The following is a description of a gene set: species: Homo sapiens Genes up-regulated in tumor associated macrophages conditioned by: glioblastoma versus colorectal adenocarcinoma. Active immunotherapy is a promising strategy for anti-angiogenic cancer therapy. Recently, we have reported that a vaccine using human umbilical vein endothelial cells (HUVECs) induced specific anti-endothelial immune responses in the most of immunized patients, and resulted in tumor regression in some patients with recurrent malignant brain tumors, whereas not in colorectal cancer patients. In this study, we hypothesized that non-hypoxic perivascular tumor associated macrophages (TAMs) in colorectal cancer, but not in glioblastoma, might negatively alter the therapeutic efficacy of anti-angiogenic active immunotherapy. To test this hypothesis, we examined global gene expression profiles of non-hypoxic macrophages stimulated in vitro by soluble factors released from tumor cells of human glioblastoma U-87MG (‘brain TAMs’) or colorectal adenocarcinoma HT-29 (‘colon TAMs’). Human Gene Set: GSE18804_BRAIN_VS_COLON_TUMORAL_MACROPHAGE_UP, and this is the list of marker genes: CYP26B1, PIGN, EDIL3, TMEM185A, DDX60L, SEM1, PSG4, TCEAL7, STOML1, SSTR5 (NCBI Gene Id 6755), BEX1, E2F7, EGR3, AMIGO1, KANSL3, BSN, OTUD1, TRIB3, PUDP, ANO2, RAB9A, EFS, PLK2, ITGB2-AS1 (NCBI Gene Id 100510549), PSMB3, MPP3, CEP41, CD70, RAB40C, MAPRE1, SCN7A, FA2H, CDKN1C, SFRP1, TBL1XR1, LMCD1, PALLD, UTY, WDR48, FUNDC1, SRRM4, ST7L, CBFB, POLR3F, MYT1, DHX40, CALB1, LINC00582, SPATA17, PSMC2, TMEM178B, LYPD6, AMPH, PIGA, LINC02381, PRRX1, SLC35A5, KCNJ4, LOXL1-AS1, SLPI, TPSD1, SSR4 (signal sequence receptor subunit 4), PPP1R9A, SYTL5, PITPNM3, PTAFR, TMCO3, B3GALNT1, ZXDC, ARPC1A (actin related protein 2/3 complex subunit 1A), ZNF83, NAP1L3, CCNL1 (cyclin L1), LPCAT2, DLG5-AS1, MIEN1, PMEL, CALCR, LRRC8D, GPNMB, BECN1, AGK, PEX11B, ELOVL7, ABLIM2, SH2D4B, KIF9, TRMT10C, CCBE1, MAGEA6 (NCBI Gene Id 94667), AMBN, TRAK1, LRRN1, TBC1D23, DNER, RNF175, KCNS3, IFT20, SAMD5, STK17A, IGHV5-78, RNF7, RTL9 (NCBI Gene Id 57529), WDR36 (NCBI Gene Id 574015), ERC1, MYEOV, CXCL10, CCN3, NATD1, AOC2, ZNHIT3, ZNF667-AS1, GDF9, PCDH19, ZBBX, KDM6B, PRRG1, FAM111A, MAGEA3, MFSD13A, SLFN12, EPHB1, RFC3, FBXO6, MYL9, DAB1, CRMP1, IL1RAPL2, NHS, MTERF2, NPRL2 (NPR2 like, GATOR1 complex subunit), RARA, ETV3, EPSTI1, CHCHD6, H1-1, CXCL6, ARMCX5, CCDC7, ZNF468, STS, WDR1, TENT5C, AP1S2, PGBD5, GRM8, NKAP, RUNX3, KDM6A, FAM32A, LCP2, F8 (NCBI Gene Id 14069), GATM, RMC1, NDUFA5, TAC1, C3orf38, PRTFDC1, TSEN15, CEP15, VAMP7, ARPC5, MSL3, MOGAT1, ZNF610, KLRC4, ATF6B, S1PR3, CHMP1B, ANXA3, LINGO3, PYROXD1, ACVR2B-AS1, KIF3C, MB21D2, CPNE4, ZNF717, VGLL3, GNG11, LAMA5, ASB9, ZIC3, IQCB1, CNPY1, PABIR1, TMOD4, LINC00665, PNPLA8, MYL7, HAPSTR2, SAAL1, TNC, RAB25